The following is a description of a gene set: species: Homo sapiens The process in which a precursor cell type acquires the specialized features of a NK T cell. Human Gene Set: GOBP_NK_T_CELL_DIFFERENTIATION, and this is the list of marker genes: FOSL2, ITK, PRDM1, AP3D1, AP3B1 (adaptor related protein complex 3 subunit beta 1), ZNF683, ATF2, TOX, TGFBR2, ZBTB16, ZBTB7B